The following is a description of a gene set: studied in species Homo sapiens Human Gene Set: REACTOME_SIGNALING_BY_ALK_IN_CANCER Signaling by ALK in cancer, and this is the list of marker genes: RNF213, TPM4, TFG, AGO2, RB1, RPS6, PIK3CA, CEBPB, UBB, KLC1, EML4, PIK3R1, GCC2, SHC1, PRKAR1A, PRF1, IRF4, AGO3, STAT1 (signal transducer and activator of transcription 1), IL10, BIRC6, MIR21, TPR, IL10RA, PPM1B, JUN, RBX1, TWIST1 (twist family bHLH transcription factor 1), NPM1, EEF1G, AGO1, WDCP, IL22, ALK, CARS1, FOXM1, GRB2, MAPK1, ZAP70, NOTCH1, SEC31A, ICOS, IRS1, CDKN1A, ATIC, ZC3HC1, PLCG1, MECP2, MDM2, VCL, CLTC, DCTN1, JUNB, RRBP1, MAPK9, MSN, FRS3, DNMT1, AGO4, LMO7, BCL11A, HDAC1, PIK3R2, TYK2, SKP1, UBA52, EIF2AK3, SQSTM1, RANBP2 (RAN binding protein 2), RPS27A, STAT5A, TPM3, CCNB1, UBC, TNRC6C, PTPN6, MOV10, MCL1, MAPK3, STRN, TP53, PIK3CB, FRS2, FN1, CUL1, MAPK8, PPFIBP1, BCL2A1, KIF5B, GZMB, HIP1, MYH9, STAT3